The following is a description of a gene set: Human Gene Set: FOXD3_01 Genes having at least one occurrence of the motif NAWTGTTTRTTT in the regions spanning 4 kb centered on their transcription starting sites. This matches the FOXD3 transcription factor binding site V$FOXD3_01 (v7.4 TRANSFAC). studied in species Homo sapiens, and this is the list of marker genes: LHX9, GFI1B, YWHAG, ANGPTL1, CYP26B1, EPHB1, FAM53B, SPMIP6 (sperm microtubule inner protein 6), CELF4, CREB5, FEZF2, CACNA1C, ATP2A2, KCNQ5, LMO3, PARP8, POU3F3, SLITRK3, CLDN8, FLOT1, IKZF3, NPNT, SIAH1, KMT2E, H2AX, FYN, KDM3A, GNAZ, GOLGA1, ZEB2, RBFOX1, CHN2, CHCHD7, HOXC6, E2F5, RREB1, TOB1, P2RY12, CNTNAP4, SYTL2, IKZF2, TLE4, CCN1 (cellular communication network factor 1), HOXA3, ID2, MARCKS, TENM3-AS1, FST, NEO1, LHX1, SGK1, CRH (NCBI Gene Id 1392), NXF4, SLC39A8 (NCBI Gene Id 64116), HOXA11, BRIP1, FSTL1, DIXDC1, SLIT3, POGZ, DNAJB7, NRAS, PIK3C2A, KCTD15, BCL6, FGFR1OP2, SLC10A7, THOC5, CITED2, TACSTD2, KCNA4, FBXO11, DTNA (NCBI Gene Id 86552), HHEX, PROC, HHIP, GTF2IRD1, HOXA10, RTL9, IL25, NR4A1, CYB561D1, PCDH17, PPP1R3C, JUNB, GRM3 (NCBI Gene Id 2913), PRIMA1, BNC2, RORA, ATOH1, EGR2, FAM107B, RUNX1T1, FOXB1, UGT1A6, COL13A1, LRRTM3, RNF128, RALGPS2, CAST, RABL6, TCF7L2, IER3, RUNX1, KLF12, SLITRK2, ANKRD28, RBP3, LMO4, PTGR3, MEF2C, MSL3, BAMBI, TBL1XR1, GET4, UTRN, NEUROD2, GNAO1, MSTN, PRICKLE2, CPNE1, CYP2A7, KRTAP11-1 (keratin associated protein 11-1), TMEM88, NRXN3, DRD3, BCL11B (BCL11 transcription factor B), STOML2, ARHGEF12 (Rho guanine nucleotide exchange factor 12), KRT222, HNF4A, PPP1CB, ZBTB37, NXF3, TSHZ2, DNTTIP1, CCDC117, IRS4, NR6A1, HTN1, OTX2, NTN1, INTS13, PCYT1B, FABP4, NFIX, ATCAY, CSNK1G3, SCUBE3, ARID4A, NOVA1, MYOCD, HESX1 (HESX homeobox 1), TWIST1, CKAP4 (NCBI Gene Id 732190), NCDN, FRMD4A, CALD1, SNCAIP, TGFB2, ANKRD11, SMAD1, ETV5, CXADR, STAG2, MESP1, TFEC, SLC22A13, AFF3 (NCBI Gene Id 3899), SCG3, CSAD, BPIFA1, ADGRB3, GPR3, FGF9, CRIM1, STARD13, NRP1, SLC44A1, RFTN2, ZHX2, GRB7, TYRO3, PLAG1, HAS2, DEPDC7, CDAN1, EVX1, RPS6KB1, NR2F1, CILK1, HAND2, LRRTM1, ACACA, KLHL1, SYT6, CYRIA, PRR34, ERRFI1, PAX8, DMD, CACNB3